The following is a description of a gene set: The process that results in the movement of cytochrome c from the mitochondrial intermembrane space into the cytosol, which is part of the apoptotic signaling pathway and leads to caspase activation. Human Gene Set: GOBP_RELEASE_OF_CYTOCHROME_C_FROM_MITOCHONDRIA studied in species Homo sapiens, and this is the list of marker genes: BNIP3, TIMM50, PSMD10, BAK1, TNFSF10, HIGD1A, BCL2L10, PRELID1, PLSCR3, PMAIP1, SFN, FAM162A, SOD2, GGCT, BID, MOAP1, TRIAP1, PARL, BIK, PINK1, TP73, NOL3, PRKN, PLAUR, GHITM, BCL2L11, BAD (NCBI Gene Id 572), MMP9, PPIF, BCL2L2, GPX1, HRK, BAX, IGF1, PYCARD, MLLT11, MCL1, BOK, BCL2A1, IFI6, CLU, SMAD3, LMNA, BMF, BCL2L1, HGF, GPER1, FZD9, ATP7A, BBC3, FXN, OPA1, TP53, BCL2, AKT1